The following is a description of a gene set: Mouse Gene Set: GOMF_DERMATAN_SULFOTRANSFERASE_ACTIVITY Catalysis of the reaction: 3'-phosphoadenylyl sulfate + dermatan = adenosine 3',5'-bisphosphate + dermatan sulfate. species: Mus musculus, and this is the list of marker genes: Chst9, Chst13, Chst11, Chst8, Chst14, Ust